Given this list of marker genes IFIT2, UBAP2L, C1orf116, KCNS3, SMAD6, PDPN, ANXA2P1 (NCBI Gene Id 90722), C17orf49, HARS2, HNRNPA1P12, CD74, PRSS8, AIM2, SPRR1A, CDKN2C, GNG12, RPS7, EPSTI1 (NCBI Gene Id 94240), DPYSL3, RARRES1 (retinoic acid receptor responder 1), PTGES, LAMC2, CHMP3, ACY1, RPL10P3 (NCBI Gene Id 619445), HNRNPA1P7, SPRR3, KIT, CASP4, TGFBR2, HNRNPA1P58, IFI44L, HLA-DRA, TCEAL8, CEP15, PON2, LGMN (NCBI Gene Id 5641), SHTN1, IFI44, CCNB1, SALL2, C1orf53, LYN, LRMDA, KYNU, CASP1, MX1, EEF2, RAB34, SERPINB8, PMCH, RPL22L1, REPIN1, ENSA, ARL14, ILF3, HNRNPA1P33, DENND11, GABBR1, TLE5, ARHGEF10, CTSE, CHMP2B, RPL22, RPS9, MMP7, TMSB10, MGST3, TMBIM4, RPL15 (NCBI Gene Id 6138), ZC3H12A, HLA-B, TSPAN3, IGF1R, PLP2, IPO7, F11R, UBE2L6, CAMK1D, AP1S1, CFB, TFB2M, PARP3, RPL4P5, CXCL10, RGS10, XAF1, DCP2, GBP2, IFIT1, IRAK2, CIRBP, SETMAR, WLS, SERTAD4, MARCKSL1, VSIG2, LTB, TAGLN2, TRNT1, KRT17P3, HNMT (NCBI Gene Id 3176), HNRNPA1P10, CD69, LPAR6, IFIT3, NFE2L3, HAS3, GPHN, MX2 (NCBI Gene Id 4600), SNCAIP, PYGL (NCBI Gene Id 5836), NSA2, NUS1, SPINK1, WDR55, RPS29 (NCBI Gene Id 6235), COPG2, PARM1, RAB32, CFAP68, IFI35, LDOC1, DLL1, OASL, CLDN23, SRSF7, IMMP2L, ECHDC2, SYT7, GBP4, TMEM158, IL32, SRI, APH1B (NCBI Gene Id 83464), PHF11, CCL20, PARP4, OAS1, C15orf48, KIF20A, FCGBP, ARMC10P1, SUB1, PTTG1, CSRP2, CTNNB1, PLLP, STARD5, NT5E (5'-nucleotidase ecto), HNRNPA3, GTF2IP4, CRTAP, CTXN1, SP110, IFITM2, TXNIP, EIF4B, RIN2, PIGM (NCBI Gene Id 93183), FAM210B, NLRP7, RHOBTB2, SQOR, LCN2, MALL, COMMD3, ADAMTS1, SYPL1, CA12, CAT, KRT17, PMPCB, EDN1, ATP1B1, UGT1A7, GSDME, HCLS1, HERC5 (HECT and RLD domain containing E3 ubiquitin protein ligase 5), HMGCS2, ANXA2, RAB27B, REG4, TP63, SERPINB1, SNAI2, PTTG3P, ENTPD3, LYPLAL1, MPZL2, NMRAL1, HNRNPA1P52, RPS27P10, SRPK2, GTF2IRD2, CXCL1, GPR15LG, SAMD9, HLA-A, QPCT, PAM, DHX9, RPL13A, CALD1, HOXD1, VPS36, SMYD3, LGALS8, IFNGR2, TOMM20, TPK1, ASS1, NUAK1, IL23A, EGFL6, IFITM3, KIFAP3, RPL15P3, IRF9, MMP10, HSD17B2, RPL12P38, C3, SORL1, HNRNPA1P4 (NCBI Gene Id 389674), RPL14, TAGLN, FERMT1, PYCARD, CTSB (NCBI Gene Id 3896), DTX3L, PODXL, SOD2, S100A9 (NCBI Gene Id 6280), BCL2, C1RL, PSMB4, MARK1, HNRNPA1P63, S1PR5, SAT1, FEZ1, ITGAV, RPL23A, TIMP1, AMOT, PLAAT4, SLC4A4, IFI6, ANXA8, RBM3, BICC1, ALDH7A1, SOCS2, BID (BH3 interacting domain death agonist), CFH, ACOT4, SSR2, UBA7, RBBP8, S100A8, PFN2, PSTPIP2, DUSP23, OAS2, STAP2, TMTC4, MST1R, MYO1D, UGT1A10, VGLL4 (vestigial like family member 4, NCBI Gene Id 9686), SLC7A2, CD44, BPGM, KLF6, NNT, SMARCC1 (NCBI Gene Id 6599), GLMP, SLC16A5 (solute carrier family 16 member 5), ANTXR1, PNMA2, LIPG, SLC66A3, HPRT1, IKBKE, HMMR, INKA1 (NCBI Gene Id 389119), IFI27, KRT16, here is a description of the gene set: from publication Jinesh GG, Kamat AM (PMID 28855211) Human Gene Set: JINESH_BLEBBISHIELD_VS_LIVE_CONTROL_DN Genes down-regulated in blebbishields compared to control RT4 live cells Apoptosis is a process that kills cells. However, cancer stem cells find ways to escape death after commencement of apoptosis. One such mechanism is blebbishield emergency program, in which the apoptotic cancer stem cells first undergo apoptotic body formation but then reassemble apoptotic bodies with main body (nuclei containing) of the apoptotic cells to form spherical to elongated structures called blebbishields. Blebbishields in turn are capable of blebbishield-blebbishield fusion to form transformed stem cell spheres (transformation phase) and then give rise to individual cancer cells from spheres (exit phase). We identified blebbishield emergency program in RT4 bladder cancer cells (RT4P=parental) and did microarray analysis of live RT4P cells, blebbishields and transformed spheres. This data set is a comparison of RT4P live cells with blebbishields and the gene list includes the genes that are downregulated in blebbishields. A separate set is provided for upregulated gene list too. In addition we provide separate gene lists for upregulated and downregulated gene lists for transformed spheres compared to blebbishields. species: Homo sapiens